The following is a description of a gene set: In this study, an extensive analysis was conducted to define meta-programs (MPs) capturing intra-tumor heterogeneity across a spectrum of tumor types. The approach utilized non-negative matrix factorization (NMF) to analyze each cell type separately within individual tumor samples. This involved the analysis of malignant cells, macrophages, fibroblasts, endothelial cells, epithelial cells, T-cells, and B-cells. NMF was executed with varying parameter values (K=4, 5, 6, 7, 8, 9), thereby generating 39 programs for each cell type per sample. Each NMF program was summarized by the top genes based on NMF coefficients.\nRobust MPs were then delineated for each cell type using a set of stringent criteria, including recurrence within the same tumor, similarity to programs in other tumors, and non-redundancy within a tumor. Subsequently, these robust NMF programs were clustered (per cell type) based on Jaccard similarity, leading to the identification of MPs associated with each cell type.\nTo enhance the quality of the MPs, a refinement steps were undertaken, involving the removal of MPs suspected of reflecting low-quality data (with an overrepresentation of ribosomal proteins or mitochondrial-encoded genes), single-study inclusion, or similarity to miss-annotated cell types. from publication Gavish A, Tyler M, Greenwald AC, Hoefflin R, Simkin D, Tschernichovsky R, Galili Darnell N, Somech E, Barbolin C, Antman T, Kovarsky D, Barrett T, Gonzalez Castro LN, Halder D, Chanoch-Myers R, Laffy J, Mints M, Wider A, Tal R, Spitzer A, Hara T, Raitses-Gurevich M, Stossel C, Golan T, Tirosh A, Suvà ML, Puram SV, Tirosh I (PMID 37258682) species: Homo sapiens Human Gene Set: GAVISH_3CA_MALIGNANT_METAPROGRAM_41_UNASSIGNED Genes upregulated in subsets of cells of a given type within various tumors, and this is the list of marker genes: GOLGA4, MLEC, EPRS1, CFLAR, SON, BPTF, PDIA4, SNORD18B, XIST, RRBP1, UBXN4, SNORD55, FNDC3B, CEP350, HIPK2, GOLGB1, EIF5B, HSP90B3P, HSP90B2P, IRF4, AKAP9, NEB, LUC7L3, MT-ND6, PNRC1, MIR3648-1, MALAT1, TTC3, PRRC2C, ZBTB38, GLCCI1, MIR6515, ZBTB20, PNISR, MEF2C, DDX5, ANKRD12, EIF3A, UTRN, HNRNPU, DST, NEAT1, DDX24, ATRX, KMT2C, NCL, KMT2A, CCDC69, SNORD68